The following is a description of a gene set: Binding to a phosphorylated tyrosine residue within a protein. Mouse Gene Set: GOMF_PHOSPHOTYROSINE_RESIDUE_BINDING studied in species Mus musculus, and this is the list of marker genes: Cbl, Pik3r2, Pfn1, Lck, Grap2, Socs3, Vav2, Pik3r3, Vav1, Shc3, Abl2, Grb2, Syk, Mapk1, Nck2, Grap, Shd, Acp2, Sh2d3c, Mapk3, Sh2d1b1, Sh3bp2, Cblc, Yes1, Stap1, Samsn1, Crkl, Rasa1, Ptpn6, Shc1, Bcar3, Plcg2, Sla, Shb, Grb10, Irs1, Cblb, Crk, Fgr, Zap70, Ldlrap1, Abl1, Ptpn5, Hck, She, Ptpn3, Pik3r1, Ptpn11